The following is a description of a gene set: Binding to a ribosomal RNA. Human Gene Set: GOMF_RRNA_BINDING species: Homo sapiens, and this is the list of marker genes: RNASEL, NPM1 (NCBI Gene Id 4869), RPF2, IMP3, NOL12, MRPL18, DDX21, UTP23, BRIX1, MRPL11, RPS3, TST (NCBI Gene Id 96794), MRPL16, RPS4X, RPL23, PPAN, RPS13, EMG1, RPS4Y2, MRPS17, RPS5, CIRBP, RPF1, MRPS18C, CAVIN1, RPL37 (ribosomal protein L37), RPLP0, FASTKD2, RPL12, MRPL20, MRPS27, MAP3K20, RPL5, RPS18, NSUN4, MRPS7, TACO1, MDM2, RPLP0P6, SBDS, MTERF4, NOP53, RPS4Y1, RPL8, RPS9, EEF2, MRPS18A, ERAL1, RPS11, RPL23A, NGRN, ANG, ERI1, FASTKD5, PTCD3, RPUSD4, DDX28, RRS1, RCC1L, KDM2B, MRPS6, UTP25, RPL9, RPL11, IMP4, GTF3A